Given this list of marker genes MACROH2A1, VRK1, HMGN3, HMGN4, MBD3, H1-9P, GATAD2B, SMARCD2, H1-7, MTA2, H1-8, H1-3, HMGA2, RBBP4, H1-1, SMARCE1, H1-10, HDAC1, SMARCC2 (NCBI Gene Id 6601), MBD2, HMGN2, H1-5, H1-2, SMARCC1, HMGN5, SMARCB1, RCC1, H3-3B, H1-4, H2AZ1, ACTB, HDAC2, SMARCA4, ACTL6A, H3-5, H1-6, H3-3A, H1-0, CHD4, HNRNPC, HMGN1, H3Y1, here is a description of the gene set: studied in species Homo sapiens Human Gene Set: GOMF_NUCLEOSOMAL_DNA_BINDING Binding to the DNA portion of a nucleosome.